The following is a description of a gene set: species: Mus musculus The removal of the apoptotic cell by phagocytosis, by a neighboring cell or by a phagocyte. Mouse Gene Set: GOBP_ENGULFMENT_OF_APOPTOTIC_CELL, and this is the list of marker genes: Abca7, Megf10, Xkr7 (NCBI Gene Id 228787), Xkr6, Becn1, Adgrb1, Alox15, Thbs1, Rac1, Xkr8 (NCBI Gene Id 381560), Xkr4, Trem2